The following is a description of a gene set: Punctate structures proximal to the endoplasmic reticulum which are the sites where the Atg machinery assembles upon autophagy induction. Human Gene Set: GOCC_PHAGOPHORE_ASSEMBLY_SITE species: Homo sapiens, and this is the list of marker genes: NBR1, ATG16L2, ATG16L1, ATG2A, SNX7, BECN1, BCAS3, ATG101, ATG9B, WIPI1 (NCBI Gene Id 55062), ULK2, WDR45, RAB33B, RAB1B, WIPI2, ULK3, ULK1, PIK3C3, SNX30, WDR45B, ATG12 (NCBI Gene Id 9140), BECN2, STX12, TAX1BP1, RB1CC1 (RB1 inducible coiled-coil 1), ATG14, RAB7A, ATG3, ILRUN, ZFYVE1, SQSTM1, ATG13, PHAF1, ATG7, ATG2B, STBD1 (NCBI Gene Id 8987), VMP1, ATG9A, ATG5